Given this list of marker genes HES1, SCRIB, SOD1, MYCL, SLITRK6, GRXCR1, RAC1, NAGLU, CLRN2, CECR2, ATP8B1, ESRP1, IFT20, MCOLN3, SLC44A4, NTRK1, USH1G, TPRN, IFT27, TRIP11, CLRN1, SDC4, MYCN, FGFR1, PAFAH1B1, PJVK, PLS1, GABRB3, MYO6, LHFPL5, NTRK3, WDPCP, JAG1, ATOH1, REST, USH1C, ELMOD3, TMC1, FGF20, NOTCH1, FZD2, SEC24B, PDZD7, HES5, GABRA5, DIAPH3, CTHRC1, SLC4A7, WHRN, IFT88, HEY2, TTC8, BMP4, GABRB2, TECTA, USH2A, MKS1, MYO7A, GRXCR2, NTF4, MINAR2, ADGRV1, TRIOBP, KCNQ1, ANKRD24, STRC (stereocilin), POU4F3, RBPJ, JAG2, TMEM132E, CDH23, TSKU, NTRK2, OTOGL, GSDME, NHERF1, VANGL2, FGF2, DLL1, here is a description of the gene set: studied in species Homo sapiens Human Gene Set: GOBP_MECHANORECEPTOR_DIFFERENTIATION The process in which a relatively unspecialized cell acquires specialized features of a mechanoreceptor, a cell specialized to transduce mechanical stimuli and relay that information centrally in the nervous system.